Given this list of marker genes C19orf12, HAUS5 (NCBI Gene Id 23354), C1orf220, BTN3A1, SCAND2P, STARD8, DLL4, SPRYD3, CRISPLD2, INMT, SZRD1, DYNC1H1, PSMD3, IL18BP, HLA-DPA1, HLA-DRB1, CECR7, AK8, LRP4, MIPOL1, APOL2, TMEM253, KLLN, MUC19, CWH43, IGHG1, DMRTB1, SPTA1, RGS22, ENO1 (NCBI Gene Id 81977), GBP1, SIK1, GBP2, PTPRD (protein tyrosine phosphatase receptor type D), ARL5C, KRTAP1-1, RPL13AP17, RANGAP1, FUT9, EPHX4, PES1, CYP51A1-AS1, TRIM56, PAX8, SLC16A1, CLDN10, CIMIP5, RHCE, HLA-DRA, SNHG29, SECTM1, OR5H1, SIPA1L3, OXCT1, HLA-B, ENAM, HTN1, GPX2, CALHM6, MRPL38, HORMAD1, ADAM5, SLC5A1, FANCA, KCNIP2, GNAO1, CBX6, C6orf132, HYOU1, S100A13, ARHGEF17, STAT1, PCDHGB5, MIR30C2, C6orf58, OOEP, CASC2, RHOC, LINC00924, RMND1, FGF14, CNKSR2, IGF2BP3, ARSL, TMEM26, MS4A3, SNORA65, WARS1, ARHGEF34P, KPTN, GGTLC2, PLEKHA7, HLA-DQB1, LIG3, LINC00216, CDK12, HLA-K, PDCD2L, DNAH10, WIZ, HS3ST3A1, PPP1R9A, GIMAP8, PSMB8, HLA-DPB1, TREX1, EPHA2, DCLK1, PLEKHO1, TRIB2, ZNF202, TENT5B, CEP41, ZNF257, ME3, SP140L, E2F7, ENPP5, PSME2, ACTRT3, RNF10, IL36RN, USP27X-DT, LINC01278, UBE2L6, LINC00029, STX5, PATE2 (NCBI Gene Id 399967), TMCO5B, APOL1, LBP, KLRD1, RPL10L, TGFB3 (NCBI Gene Id 7043), LINC01973, PLAAT4, ZNF669, SLC8A1-AS1, ICAM2, OR2M4, RBFOX2, RNF126P1, BNIP1, OR4D1, ANOS1, CDR2, SIM1, ARFRP1 (NCBI Gene Id 149661), ACSBG2, EPN2, HLA-DRB6, DNPEP, CSHL1, TRAFD1, PTTG1, DRP2, GSDMD, CD74, PIGL (phosphatidylinositol glycan anchor biosynthesis class L), TNF, WBP2NL, TMEM161B-DT, NLRC5, PTCHD4, HLA-A, UPB1, PAK3, VPS9D1, ZNF423, SLC17A8, RAB4B, MARVELD2, ADH1A, CEP57L1, LRRN4CL, MYBL1, PTP4A3, OSBPL3, ZNFX1, IL12RB1, KCNJ8, MYH3 (myosin heavy chain 3), SCNN1D, ZNF479, GYS2, STK31, TP53AIP1, ARHGEF26-AS1, HCAR3, KRTAP4-3, HNRNPA1L2, SLC9C2, INHBA, here is a description of the gene set: species: Homo sapiens from publication Pfeffer LM, Kim JG, Pfeffer SR, Carrigan DJ, Baker DP, Wei L, Homayouni R (PMID 15131130) Genes down-regulated in mouse embryonic fibroblasts (MEF): untreated versus interferon beta. Human Gene Set: GSE3400_UNTREATED_VS_IFNB_TREATED_MEF_DN A number of IFN-induced proteins are believed to be responsible for the antiviral state induced by IFNs. Our microarray analysis of IFN-regulated genes in MEFs from wild-type mice identified 124 probe sets that were differentially regulated upon IFN treatment. This group consisted of many known ISGs such as Ifit1, Gbp2, mx1, Isg15, Stat1, nmi, mx2, If204, Adar, Irf1, and protein kinase R.